The following is a description of a gene set: Genes up-regulated in peripheral blood mononuclear cell low responders vs high responders in adults (18-55) after exposure to Modified Vaccinia Ankara (MVA) virus vaccine vector, time point 2D. Comment: Enriched for GO terms associated with regulation of T-cell activation and co-stimulation signal (DAVID, fdr<0.05), from 176 DE genes Human Gene Set: MATSUMIYA_PBMC_MODIFIED_VACCINIA_ANKARA_VACCINE_AGE_18_55YO_LOW_VS_HIGH_RESPONDERS_2DY_GO_T_CELL_ACTIV_AND_CO_STIM_UP from publication Matsumiya M, Stylianou E, Griffiths K, Lang Z, Meyer J, Harris SA, Rowland R, Minassian AM, Pathan AA, Fletcher H, McShane H (PMID 23844129) A better understanding of the relationships between vaccine, immunogenicity and protection from disease would greatly facilitate vaccine development. Modified vaccinia virus Ankara expressing antigen 85A (MVA85A) is a novel tuberculosis vaccine candidate designed to enhance responses induced by BCG. Antigen-specific interferon-gamma (IFN-gamma) production is greatly enhanced by MVA85A, however the variability between healthy individuals is extensive. In this study we have sought to characterize the early changes in gene expression in humans following vaccination with MVA85A and relate these to long-term immunogenicity. Two days post-vaccination, MVA85A induces a strong interferon and inflammatory response. Separating volunteers into high and low responders on the basis of T cell responses to 85A peptides measured during the trial, an expansion of circulating CD4+ CD25+ Foxp3+ cells is seen in low but not high responders. Additionally, high levels of Toll-like Receptor (TLR) 1 on day of vaccination are associated with an increased response to antigen 85A. In a classification model, combined expression levels of TLR1, TICAM2 and CD14 on day of vaccination and CTLA4 and IL2Ralpha two days post-vaccination can classify high and low responders with over 80% accuracy. Furthermore, administering MVA85A in mice with anti-TLR2 antibodies may abrogate high responses, and neutralising antibodies to TLRs 1, 2 or 6 or HMGB1 decrease CXCL2 production during in vitro stimulation with MVA85A. HMGB1 is released into the supernatant following atimulation with MVA85A and we propose this signal may be the trigger activating the TLR pathway. This study suggests an important role for an endogenous ligand in innate sensing of MVA and demonstrates the importance of pattern recognition receptors and regulatory T cell responses in determining the magnitude of the antigen specific immune response to vaccination with MVA85A in humans. species: Homo sapiens, and this is the list of marker genes: STAT5B, IL2RA, CD5, CD3D, ITK, CD2, CTLA4, TRAT1, CD28, DNAJA3